Given this list of marker genes Nek1, H3f3b, Klrb1b, Hdgfl1, Rab24, Rbbp4, Tnpo2, Dcun1d3, Telo2 (NCBI Gene Id 71718), Slc35d1, Pfkl, Hey1, Hmgcs1, Plekhh1, Trabd2b, Rorb, Cnot9, Cux1, Kpna4, Ccdc6, Vapb, Ptger4, Chordc1, Cfap300, Ndufb11b, Sec14l1, Nt5e, Amigo1, Stac2 (SH3 and cysteine rich domain 2), Anks1, Ckm, here is a description of the gene set: species: Mus musculus from publication Chen Y, Wang X (PMID 31504780) Genes predicted to be targets of miRBase v22 microRNA mmu_miR_292b_3p in miRDB v6.0 with MirTarget v4 prediction scores > 80 (high confidence targets). Mouse Gene Set: MIR_292B_3P